Given this list of marker genes KIF16B, GABPA, TPP2, ZNF274, TTC13, BPNT1 (3'(2'), 5'-bisphosphate nucleotidase 1), CD40, ABRACL, MRPL57, FTL, ERAP1, SSNA1, MCFD2, ZFP64, UTP18, CTPS1, CLNS1A, TMED10, LIPT2, MYLIP, CCT4, CRIPT, ZNF334, CYB5R3, NUDT5, TTI1, CEBPA (NCBI Gene Id 1050), OSBPL2, KPNA1, TSR2, IGF1, CENPB, FBXO33, ACOT7, LSM3, RAB18, DHRS7B, PABIR1, DIABLO, WDR4, MRPL23, CPEB2, ITGB1, PREPL, PEX7, ATG9B (NCBI Gene Id 442783), DNAJA3, VAMP2, NOSIP, ARL8B, GHITM, CRTAP, SNRPA1, UBE2K, NGLY1, CERS2, NSMF, POLR1A, UTP20, OARD1 (O-acyl-ADP-ribose deacylase 1), POGLUT1, DNAJC2 (NCBI Gene Id 378162), POLR2B, RBMX, EMC4, OAT, NMT2, SERPINE2, TPRKB, SLC28A2, MAOA, FAM133B, IARS1, NCF4, ELOC, FLVCR2, NCKAP1, NCBP2, CKS2, TUBB2A, CHST14, GSTM3, PIWIL1, SOX18, GPAM, CHADL, EIF4E, POLR3K, SUOX, PIBF1, ARPC1A, CLEC4D, SRSF6, CAV1, RHBDD1, GATM, NUP50, CCL13, ID3, ATP5F1B, CCDC117, TESK1, AP1AR, SLC35A4, ADORA1, RRP15, ATP2A2 (ATPase sarcoplasmic/endoplasmic reticulum Ca2+ transporting 2), PSMC1, SMIM30, FASTKD2, KCTD1, IMP3, KLHL26, HLA-C, CDC45, ZDHHC12 (zinc finger DHHC-type palmitoyltransferase 12), HHIP, PLGRKT, ADAM19, LUC7L, PITHD1, NFATC4, TAGLN2, SNRPD2, GFER, STAG1, ALDH1A2, GTPBP4, AP2M1, FBXO22, TP53BP1, SMAP1, PPIF, CCDC71L (coiled-coil domain containing 71 like), ERGIC3, RBM18, ENTR1, CNTN4, C16orf87, IER5, GMPR2, CKS1B, ITGAL, ZNF444, WLS, ADAM17, ZNF644, HEATR6, COX6B1, HEATR1, COX19, NOP56, CNGA2, POLR3D, ARL1, STARD7, EIF4H, UBE2A, MRPS2, HERPUD1, RCN1, IGF2BP1, MRPS28, KPNB1, PRKAR1A, LSM10, SYNCRIP, GRAP2, PDZD11, ADA, LCP1, PBDC1, SRM, KDELR2, PRR13, ZMYM1, PDZK1IP1, SUCO, SDHD, RPL5, TSHZ1, HERC2, GABARAP, GTF2H4, MRPS16, ETFRF1 (NCBI Gene Id 144363), HNRNPDL, HSP90B1, ARPC4, TEX10, TLR8, RGS19, FAM162A, SPCS1, TRMT112, ZNF287, MORF4L2, INHBA, COPS3, here is a description of the gene set: mouse primary BMDCs were stimulated with tlr ligands and gene expression changes were profiled on Affymetrix arrays from publication Amit I, Garber M, Chevrier N, Leite AP, Donner Y, Eisenhaure T, Guttman M, Grenier JK, Li W, Zuk O, Schubert LA, Birditt B, Shay T, Goren A, Zhang X, Smith Z, Deering R, McDonald RC, Cabili M, Bernstein BE, Rinn JL, Meissner A, Root DE, Hacohen N, Regev A (PMID 19729616) species: Homo sapiens Human Gene Set: GSE17721_POLYIC_VS_CPG_8H_BMDC_DN Genes down-regulated in comparison of dendritic cells (DC) stimulated with poly(I:C) (TLR3 agonist) at 8 h versus DC cells stimulated with CpG DNA (TLR9 agonist) at 8 h.